The following is a description of a gene set: Abnormal dermoepidermal junction morphology Human Gene Set: HP_ABNORMAL_DERMOEPIDERMAL_JUNCTION_MORPHOLOGY studied in species Homo sapiens Any anomaly of the structure of the acellular zone that is between the dermis and the epidermis and which functions to bind the epidermis to the dermis and to serve as a selective barrier allowing the control of molecular and cellular exchanges between the two compartments., and this is the list of marker genes: LAMA3, JUP, ZAP70, KRT14, ITGB4, COL17A1, PLEC, DST, DSP, ITGA6, LAMB3, LAMC2